Given this list of marker genes Ifngr1, Rhoj, Itga6, Cd82, Gpr4, Rras, Jcad, Pld1, Il12rb2, Stard13, Idh2, Anxa1, Arhgef4, Cav2, Il1b, Mmrn2, Il1a, Aggf1, Ntn4, S1pr2, Peak1, Dock4, H2ax, Amotl1 (angiomotin-like 1), Ccm2l, Adamts12, Myct1, Fkbpl, Itgb3, here is a description of the gene set: Mouse genes annotated to abnormal tumor vascularization (MP:0010144) retrieved from the Mouse Genome Informatics database via MouseMine Mouse Gene Set: MP_ABNORMAL_TUMOR_VASCULARIZATION studied in species Mus musculus from publication Motenko H, Neuhauser SB, O'Keefe M, Richardson JE (PMID 26092688)